Given this list of marker genes NKIRAS2, NFKBIA, RIPK1, ZBP1, RIPK3 (receptor interacting serine/threonine kinase 3), TLR3, IKBKB, TICAM1, RELA, IKBKG, NFKB2, DHX9, NFKBIB, CHUK, NFKB1, NKIRAS1, MYD88, here is a description of the gene set: Overexpression of human or murine ZBP1 (DAI) in human embryonic kidney 293T cells (HEK293T) activated NF-kB-dependent promoter in a dose-dependent manner. Two RHIM-contaning kinases RIP1 and RIP3 are implicated in ZBP1-induced NFkB activation (Rebsamen M et al 2009; Kaiser WJ et al 2008). studied in species Homo sapiens Reactome Pathway: RIP-mediated NFkB activation via ZBP1 part of: ZBP1(DAI) mediated induction of type I IFNs